The following is a description of a gene set: Any process that activates, maintains or increases the rate of skeletal muscle fiber development. Muscle fibers are formed by the maturation of myotubes. They can be classed as slow, intermediate/fast or fast. studied in species Homo sapiens Human Gene Set: GOBP_POSITIVE_REGULATION_OF_SKELETAL_MUSCLE_FIBER_DEVELOPMENT, and this is the list of marker genes: ACTN3, LMOD3, MYF6, SHOX2 (NCBI Gene Id 6474), MYOG, BCL2, MYF5, MYOD1